Given this list of marker genes DLD, AASS, SLC25A21 (solute carrier family 25 member 21), CRYM, DLST, DHTKD1, PHYKPL, ALDH7A1 (NCBI Gene Id 64414, aldehyde dehydrogenase 7 family member A1), AADAT, PIPOX, HYKK, GCDH, here is a description of the gene set: Reactome Pathway: Lysine catabolism species: Homo sapiens part of: Metabolism of amino acids and derivatives In humans, most catabolism of L-lysine normally proceeds via a sequence of seven reactions which feeds into the pathway for fatty acid catabolism. In the first two reactions, catalyzed by a single enzyme complex, lysine is combined with alpha-ketoglutarate to form saccharopine, which in turn is cleaved and oxidized to yield glutamate and alpha-ketoadipic semialdehyde. The latter molecule is further oxidized to alpha-ketoadipate. Alpha-ketoadipate is oxidatively decarboxylated by the alpha-ketoglutarate dehydrogenase complex (the same enzyme complex responsible for the conversion of alpha-ketoglutarate to succinyl-CoA in the citric acid cycle), yielding glutaryl-CoA. Glutaryl-CoA is converted to crotonyl-CoA, crotonyl-CoA is converted to beta-hydroxybutyryl-CoA, and beta-hydroxybutyryl-CoA is converted to acetoacetyl-CoA. The products of lysine catabolism are thus exclusively ketogenic; i.e., under starvation conditions they can be used for the synthesis of ketone bodies, beta-hydroxybutyrate and acetoacetate, but not for the net synthesis of glucose.